Given this list of marker genes CALM1, MAP2, CYP1A2, PER3, BMAL1, MTNR1A, MTNR1B, SULT1A1, AANAT, NFKB1, ASMT (NCBI Gene Id 8278), CRY2, MIR126, SIRT1, FOXO1, ACHE, CYP2C19, IRAK1, CYP2D6, APOE, MAOA, CYP1B1, PER2 (period circadian regulator 2), MIR146A, CAMK2A, PER1, GSK3B, TRAF6, CYP1A1, CSNK1E, ECE1, CLOCK, CRY1, EDN1, PRKCA, CSNK1D, ADRB1, here is a description of the gene set: Melatonin metabolism and effects Human Gene Set: WP_MELATONIN_METABOLISM_AND_EFFECTS studied in species Homo sapiens